Given this list of marker genes SKA2, PSMB1, PPP2R5C, YWHAE, NUP133, H4C3, TUBGCP2, CENPJ, PSMD12, SPAST, CHMP2A, CSNK1D, TAOK1, SEH1L, RAB1A, H3C8, H2BC8, BANF1, EML4, H2AC19, RAD21 (NCBI Gene Id 5885), PDS5B, TUBA1C, SMC4, H3C11, RANBP2, BIRC5, H2BC26 (H2B clustered histone 26), NIPBL, INCENP, ANAPC1, H2AZ2, NUP85, NUP35, TUBGCP6, ALMS1, H2BC10 (NCBI Gene Id 8346), H2BC13, CENPO, TUBGCP5, AAAS, H2AC14, POM121, PSMB6, CDC20, TUBAL3, ANAPC10, CSNK2A1, SPC25, H2BC4, KIF18A, UBC, MAPK1, NEK6, H3-3A, BLZF1, KIF2A, CENPT, TUBA1A, NUP98, HAUS2, RAE1, PPP2R1A, UBE2D1, CEP70, CCNB2, H3C7, ERCC6L, H4C13, PRKCB, PPP1CC, H3C4, PRKAR2B, TUBB2B, NDC1, SIRT2, PPP2R5B, H2BC1, CSNK1E, LBR, MCPH1 (NCBI Gene Id 79648), NCAPD3, H3C2, KNL1, PSMB5, UBE2S, TUBA8, NUF2, PMF1, RCC2, OFD1, CEP63, MZT1, RANGAP1, H4C1, RAB2A, KIF2C, TUBB8B, SGO1, ESPL1, H4C5, DYNC1I2, IST1, H3C13, H4C11, AHCTF1, SDCCAG8, PAFAH1B1, TUBA3E (tubulin alpha 3e), CKAP5, TUBA3C, TUBB4B, DYNC1I1, H2BC11, FBXO5, H4C4, H2BC7, CDC16, H2BC9, PLK4, PSMD3 (NCBI Gene Id 94019), CHMP4B, DYNC1LI2, LEMD3, UBB, CDK5RAP2, NEK9, CENPE (NCBI Gene Id 1062), NUP205, UBA52, TUBB4A, HAUS7, PDS5A, SEC13, CLASP1, H4C15, SPDL1, CDC27, SMC2, H2BC21, PSMA3, MAD2L1, NUP88, H4C14, PSMD1, PPP2CA, PRKACA, NUP155, SMC3, NEK2, NUMA1, STAG1, NEK7, CSNK2B, CENPC, LMNA, ZWINT, NUP54, H3C3, TUBB1 (tubulin beta 1 class VI), UBE2E1, ANAPC4, PSMB3, H2AC7 (H2A clustered histone 7), HDAC8, GOLGA2, CHMP7, SET, KIF2B, H3C15, H2BC15, RCC1, H2BC17, NUP93, SGO2, H3-4, LMNB1, PCM1, TMPO, SKA1, CHMP3, TUBA4A, H4C9, BUB1B, CEP43 (centrosomal protein 43), ZWILCH, PSMD8, PPP2CB, DYNLL1, MIS12, NUP50, CEP164, PSMA4, SPC24, PSMC1, VRK2, ARPP19, HAUS1, CHMP4A, NDEL1 (NCBI Gene Id 81565), CC2D1B, TUBB6, MZT2B, CEP135, B9D2, H3C6, MASTL, NSL1, SFI1, NUP107, PSMD13, LPIN2, CEP250, ACTR1A, H2BC14, TUBA4B, CENPA, CENPH, CDCA5 (NCBI Gene Id 256676), MAD1L1, CCNB1, RAN, PSMC5, ANAPC16, NUP210 (NCBI Gene Id 79985), DCTN1, DCTN3, H2AC4, LPIN1, H3C1 (NCBI Gene Id 8350), DYNLL2, CEP78, PSMC3, EMD, CHMP6, PTTG1, H3-3B, GORASP1, HAUS5, H2AC18, CENPK, CHMP4C, SEM1, PHF8, H3C14, AURKB, NUP42, H2BC12, YWHAG, MZT2A, NUP37, NME7, ODF2, H2AJ, NUP58, VRK1, CLASP2, ANAPC5, NEDD1, H2BC3, PPP2R5D, NDC80, DCTN2, CDCA8, CENPP, CNEP1R1, ENSA, H4C12, H2BC12L, TUBGCP3, PSMD2, DSN1, PCNT, TUBG2 (tubulin gamma 2), CEP131, SUMO1, CDC23, CTDNEP1, CEP290, H2AC6, UBE2C, TUBB3, CLIP1, ANAPC11, PSMD6, ANAPC7, LPIN3 (NCBI Gene Id 64900), CENPI, PLK1, XPO1, CEP76, STAG2, NUP214, NCAPG2, NCAPD2, RPS27 (NCBI Gene Id 6232), CENPS, PSMD14, H4C8, LEMD2 (LEM domain nuclear envelope protein 2), NUP188, PSMC6, HAUS6, PSMA7, CENPM, PSMA1, H4C2, KNTC1, UBE2I, NUDC, DYNC1H1, NUP160, RAB1B (RAB1B, member RAS oncogene family), NCAPH2, HAUS3, CETN2, PSMB7, ZW10, AKAP9, H2AC20, CDC26, PSMD7, PSMA5, SMC1A, TUBG1, CEP72, CCP110, CENPL, KMT5A, PSMA6, MAPK3, H2AC8, HSP90AA1, HAUS8 (HAUS augmin like complex subunit 8), VPS4A, TNPO1, CENPU, CENPF, HAUS4, PSMC4, PPP2R5A, H2BC6, NDE1, H4C16, PPP2R2D, ANAPC2, PPP2R1B, PPP2R2A, TUBA3D, BUB3 (BUB3 mitotic checkpoint protein), PSMD11, H2BC5, MAPRE1, TPR, CEP192, FIRRM, CNTRL, NUP153, WAPL, PRKCA, CSNK2A2, KPNB1, NCAPG, ADRM1, SSNA1, TUBB2A, MAU2 (NCBI Gene Id 23383), H2AB1, DYNC1LI1, H3C12, GORASP2, CHMP2B, CEP57, PSMB2, ANKLE2, PSMB4, KIF20A, TUBB, PPP2R5E, RPS27A, CEP41, NCAPH, TUBA1B, USO1, CDK1, TUBGCP4, PSMA2, NUP43, POM121C, CENPN, RB1, CEP152, NINL, H3C10, KIF23, H4C6 (NCBI Gene Id 8361), CENPQ, NUP62, ITGB3BP, PSMC2, ANAPC15, TUBB8, H2AX, BUB1, here is a description of the gene set: species: Homo sapiens Human Gene Set: REACTOME_M_PHASE M Phase